The following is a description of a gene set: A process that is carried out at the cellular level which results in the assembly, arrangement of constituent parts, or disassembly of a microvillus, a thin cylindrical membrane-covered projection on the surface of a cell. species: Mus musculus Mouse Gene Set: GOBP_MICROVILLUS_ORGANIZATION, and this is the list of marker genes: Stx2, Myo1a, Ezr, Klf5, Gldn, Ptpn11, Twf2 (twinfilin actin binding protein 2), Tnik, Espn, Rapgef2, Ush1c, Rap2a, Pls1, Cdhr2, Hnf4a, Pld1, Podxl, Vil1, Rdx (radixin), Fscn1, Stk26, Rap1gap, Prl2c2, Cdhr5, Rapgef6, Nherf1, Atp8b1